The following is a description of a gene set: Human Gene Set: HP_DECREASED_ACTIVITY_OF_MITOCHONDRIAL_ATP_SYNTHASE_COMPLEX Decreased activity of mitochondrial ATP synthase complex A reduction in the activity of the mitochondrial proton-transporting ATP synthase complex, which makes ATP via oxidative phosphorylation, and is sometimes described as Complex V of the electron transport chain. studied in species Homo sapiens, and this is the list of marker genes: FBXL4, ATP5F1D, ATP5F1A, GFM1, TK2, ATPAF2, MRPS16 (NCBI Gene Id 64959), ATP5F1E (NCBI Gene Id 514), MRPS14, MRPS22, TIMM50, MTRFR, TMEM70